Given this list of marker genes Abl1, Ankrd6, Nkd1, Mllt3, Gpc3, Abl2, Plekha4, Dab2, here is a description of the gene set: Any process that activates or increases the frequency, rate or extent of Wnt signaling pathway, planar cell polarity pathway. Mouse Gene Set: GOBP_POSITIVE_REGULATION_OF_WNT_SIGNALING_PATHWAY_PLANAR_CELL_POLARITY_PATHWAY species: Mus musculus